The following is a description of a gene set: The smaller subcomplex of the intraciliary transport particle; characterized complexes have molecular weights of 710-760 kDa. studied in species Mus musculus Mouse Gene Set: GOCC_INTRACILIARY_TRANSPORT_PARTICLE_A, and this is the list of marker genes: Ttc21a, Ift140, Wdr19, Ift43, Wdr35, Ift122, Cluap1, Ttc21b